Given this list of marker genes ORC1, GTF3C3, CCT7, CD99, LDLRAD4, PON2, CHD9, RHOA, DLD, RFC1, STK38L, PAICS (phosphoribosylaminoimidazole carboxylase and phosphoribosylaminoimidazolesuccinocarboxamide synthase), ACTG1, IDE, CDC20, TARP, NREP, PTP4A2, BAZ2B, TCEAL9, TCEA1, GNMT, CSNK2A1, NINL, SLC35A5, ABHD10, TOR1B (NCBI Gene Id 84822), IMMT, MAD2L1, TUBB, ORC6, CHST10, CENPE, RAD51C, ZWINT, TXNDC9, DET1, IMPA2, COPB2, HSD17B4, GARS1, DYNC1I2, STMN1, GMNN, BAZ1B, RFX5, CBX3, ALG9, PSMD14, HIVEP3, DSG2, GTF2A2, ELN, ENSA, RUVBL1, SCRN1, TIMELESS, CDCA4, NUBPL, PGRMC1, SND1, ETF1, TOPBP1, TRDMT1, RRAS2, RPGRIP1L, GDE1, FKBP3, GOT1, GSTO1 (NCBI Gene Id 9446), SPAG1, FEN1, GINS1, TDP1, MCM6, UBE2E3, FOCAD, TCF12, GABPA, USPL1, VPS26A, SRSF9 (serine and arginine rich splicing factor 9), GNG11, PSIP1, PA2G4, RAB32, AAGAB, MFAP4, EEF1A1, ARMCX1, STIL, TFRC (NCBI Gene Id 7037), IMPDH2, RNFT2, MCAM, FAIM, PRPF8, UPF2, RNASEH2B, GOT2, TPGS2, STK32B, ANXA4, CBX1, CUL1, MICU1 (NCBI Gene Id 51415), RHEB, EIF4A1, GAS7, MRPL11 (mitochondrial ribosomal protein L11), PPP4R1, FIRRM, STN1, RAP1GDS1, ADNP2, PRC1, PSMA6 (proteasome 20S subunit alpha 6), SNAP29, PGD, MIS18A, DDX1, PTPN2, CHCHD3, MRPS22, CD2AP, STS, KIF2C, THUMPD2, GORASP2, LYRM1, DNAJB6, SMC2, SMAD2, TP53BP2, POLE3, MYBL2, SF3A3, AHI1, FBXO5, USP1, HES1, MFAP1, CCR9, MSH2, CFH, HMGB2, ADA, CCT5, UBAP2, PNMA1, FABP5, MPP1, TXN, ATP6V1C1 (ATPase H+ transporting V1 subunit C1), KCTD9, VIPAS39, GMPR2, SCN9A, HNRNPR, PSAP, PCNA, AIFM1, UBR7, NSDHL, ADH5, UCK2, MYL6B, SNRNP40, HNRNPH1, PRR11, DENR, UBE4B (NCBI Gene Id 10277), TCERG1, TRO, HNRNPA0, RUBCNL (rubicon like autophagy enhancer), CNBP, ETS2, ERLIN1, CCNA2, ELP3, IDH3A, TNFRSF21, HNRNPAB, PLK4, HADH, TIMP2 (TIMP metallopeptidase inhibitor 2), PCCB, RRM1, SIGMAR1, TM7SF3, CTPS2, RMI1, VIM, H4C3, TXNRD1, TRIP13, SCN3A, GNL2, IFI16, here is a description of the gene set: Genes up-regulated in comparison of intrathymic T progenitor cells (ITTP) versus naive CD4 T cells from cord blood. from publication Lee MS, Hanspers K, Barker CS, Korn AP, McCune JM (PMID 15210650) studied in species Homo sapiens Subpopulations of human fetal thymocyte and circulating naïve T cells were obtained through FACS sorting, including CD3-CD4+CD8- intrathymic T progenitor cells (ITTP), CD3intCD4+CD8+ \double positive\ thymocytes (DP), CD3highCD4+CD8- \single positive\ thymocytes (SP4), CD3+CD4+CD8-CD45RA+CD62L+ naive T cells from cord blood (CB4+), and CD3+CD4+CD8-CD45RA+CD62L+ naive T cells from adult blood (AB4+). Human Gene Set: GSE1460_INTRATHYMIC_T_PROGENITOR_VS_NAIVE_CD4_TCELL_CORD_BLOOD_UP